The following is a description of a gene set: Human Gene Set: GOBP_NEGATIVE_REGULATION_OF_DNA_BINDING species: Homo sapiens Any process that stops or reduces the frequency, rate or extent of DNA binding. DNA binding is any process in which a gene product interacts selectively with DNA (deoxyribonucleic acid)., and this is the list of marker genes: SUMO1, CPNE1, ZNF593, SMO, TNKS, IFI16, MDFI, PSEN1, RSF1, SUMO3, HEY2, TFAP4, SOX11, ILRUN, HMGA2, JUN, GATA1, SUMO4, LEF1, GZMA, NFIB, E2F1